Given this list of marker genes Zfta, Gna14, Gm31166, Tex54, Gm14963, Hnrnpul2 (heterogeneous nuclear ribonucleoprotein U-like 2), Gal, Gstp2, Vwce, Or5b108 (NCBI Gene Id 258688), Gm19224, Ppp2r5b, Gm22272, Fads1, Rpl37-ps1, Nrxn2, Slc29a2, Gm30082, B4gat1, Nscme3l, Dpp3, Or10v9, Dtx4, Or9i16, Cabp4, Or5b99, Tcirg1, Nudt22, Ms4a6d, Gm18842, Mir6984, Eml3, Or10q3, Snora57, Top6bl, Gm7798, Or9i1b, 2210404E10Rik, Gm31070, Ms4a4d, Cfl1, AW112010, Or5an8-ps1, 1700061A03Rik, Tbx10, Gm42068, Mir496b, Wdr74, Ehbp1l1, Ms4a5, Gm25894, D330050I16Rik (RIKEN cDNA D330050I16 gene), Or5b110-ps1, Gm22680, Yif1a, B3gat3, Gm15967, Mrpl21, Cnih2, Gm9750, Olfr1435-ps1, Zfpl1, Clcf1, Tut1, Gm5513, Or5b118, Cpt1a, Gm8184, Syt12, Flrt1, Zbtb3, Or4d11, Keg1, Tmem258, Stx3, Cep78, Kcnk4, Tmem179b, Ms4a8a, Slc3a2, Sart1, Rbm4b, Slc22a29, Snhg1, Gm17068, Slc25a45, Fen1, Ptgdr2, Slc22a12, Gm53055, Scyl1, Banf1, Eif1ad, Nudt8, Or5aa2-ps1, Lpxn, Or5b12, Batf2, Gm6192, Lbhd1, 4930524O05Rik, Vps37c, Or10w1, Tmem216, Ndufv1, Olfr1488-ps1, 4930526L06Rik, Ms4a4a, Ms4a3, Eef1g, Tmem132a, Cdca5, Atl3, Tm7sf2, Map3k11, Gm7096, Or5a1, Rbm4, Olfr1481-ps1, Ighmbp2, Rps6kb2, Syt7, Ms4a15, Asrgl1 (asparaginase like 1), Efemp2, Cdc42bpg, Gpr152, Ccdc87, Or5b94, Or5b113, 1810055G02Rik, Or5q1-ps1, Coro1b, Mir6988, Gm8034, Mir6994, Ppp6r3, Ptprcap, Majin, Or5b12b, Plaat5 (NCBI Gene Id 73514, phospholipase A and acyltransferase 5), Or5an10, Brms1, Gm10814, Atg2a, Dpf2, Kcnk7, Bscl2, Mir192, Bbs1, Or10q12, Tmem151a, Mir194-2, Scgb1a1, Gm5242, Tbc1d10c, Tmem134, Fermt3, Chrm1, Aip, Stxbp3-ps, Esrra, Gm8369, Or5a3, Or4d29-ps1, Ms4a14, Znhit2, A430093F15Rik, Ppp1ca, Or5bb10, Or5b116, Gm8189, Or5an1b, Or5x2-ps1, Grk2, Lgals12, Malat1, Or5b96, Ms4a13, Or5b124, Psat1, Mta2, Fam89b, Neat1, Gm23246, Ms4a20, Or9i13-ps1, Gm3188, Gm44505, Ms4a12, Pcx, Ap5b1, Nxf1, Or9i1, Fads3, Drap1, Ints5, Ms4a4b, Ccdc86, Or5b121, Or9i14, Rnaseh2c, Mpeg1, Stip1, Rad9a, Ctsf, Carns1, Kmt5b, Oosp2, Aldh3b3, Tle4, Or5b117, Pfpl, Trmt112, Or5b101, Snx32, Klc2, Lrp5, Or5x1-ps1, Rbm14 (NCBI Gene Id 71771, RNA binding motif protein 14), Snord3b-ps1, Vps51, Or5a21, Slc22a26, Npas4, Mus81, Or5b109, Rplp1rt, Or10q1, Or5aa3-ps1, A930001C03Rik, Mir6989, Zp1, Or5b100-ps1, Fau, Gm36608, Gm49405, Snord22, Acy3, Ms4a2, Aldh3b2, Sf3b2, BE692007, Gm24452, A330040F15Rik, Gm10817, Ahnak, Uqcc3, Gm46658, Prpf19, Gm50359, Cpsf7, Oosp1, Gm550, Gpr137, Ms4a4c, 2410152P15Rik, Gm22744, Or5b97, Or10w3, Gm10819, Slc22a8, Dnajc4, AI837181, Fosl1, Hmgb1-ps4, Tesmin, Gm19312, Or5b3, Plcb3, Oosp3, Or5b102, Ccs, Or5an1, Gm30042, Slc22a20, Gm2106, Olfr1482-ps1, Or5an11, Gm6425, Or5b122, Cblif, Or4d6, Tmem223, Gm5512, Scgb2a2, Mir6991, 1700030N03Rik, Gstp1, Cd6, Gm5510, Gm25443, Tkfc, Naaladl1, Gm17552, Olfr1421-ps1, Men1, Tmem109, Slc22a19, Mrpl11, Or5b95, Tsga10ip, Slc22a6 (solute carrier family 22 (organic anion transporter), member 6), Ovol1, Gm6501, Rin1, 1500032F14Rik, Or5b119, Gpha2, Gm5511, Ganab (NCBI Gene Id 14376), Ehd1, Rom1, Or5b107, Ccdc85b, Tmem138, Gm16437, Mrpl16, Ankrd13d, Cd5, Pcna-ps2, Rce1, Mrpl49, Gm24124, Taf6l (TATA-box binding protein associated factor 6 like), Or4d10b, Gm10353, Ppp1r14b, Ltbp3, Plaat3 (phospholipase A and acyltransferase 3), Zdhhc24, Or5bb12, Saxo4, Pitpnm1, Gm16274, Or10v5, Gm3329, Gm15968, Lrrc10b, Or5aa1-ps1, Sdhaf2, Or5u1-ps1, Or10q1b, Cd248, Mir5136, Or5b98, Capn1, Gm336, Ccdc88b, Gm25432, Gm50432, Or9i2, Mir5046, Gm16066, Best1, Kat5, Mir6990, Rcor2, Spindoc, Map4k2, Kdm2a, Gm17802, Gm10802, Or4d10, Fkbp2, Or10v1, 2010003K11Rik, Arl2 (NCBI Gene Id 80563), Rasgrp2, Or5b106, Gm2141, Myrf, Gnaq, Rhod, Osbp, Gm36787, Syvn1 (synovial apoptosis inhibitor 1, synoviolin), Zfp91, Ndufs8, Gm45928, Lrfn4, Slc22a30, Or5an6, Ddb1, Mir6985, Mir6986, Or5b120, Mir6992, Polr2g, Ms4a6c, Or5b115-ps1, Pygm, Gm26183, Gm24521, Or5b123, 4930481A15Rik, Macrod1, Gm42064, Aldh3b1, Gm42067, Gm6445, Or9d1-ps1, Gm24453, Bad, Gm14966, Gm2617, Or5b103-ps1, Or9i15-ps1, Tmem262, Gstp3, Gm28347, Gm25855, Gm19261, Snx15 (NCBI Gene Id 69024), Or5an1c, Sf1, Unc93b1, Ms4a18, Or5an9, Gm7105, Dagla, Gm6386, Or5b125-ps1, Vegfb, Otub1, Gm41804, Or9q2, Trpt1, Cdk2ap2, Fth1, Ms4a6b, Ms4a7, Gm14964, Gm4952, Or5b21 (olfactory receptor family 5 subfamily B member 21), Fads2, Ubxn1, Mir6987, Cdc42ep2, Gm19209, Sac3d1, Pga5, Prdx5, Chka, Cox8a, Ctsw, 1810009A15Rik, Slc22a27, Gm10212 (NCBI Gene Id 101055836), Stx5a, Gm6293, Tigd3, Or5b112, Gal3st3, Pola2, Rab11b-ps2, Slc22a28, Gm2518, Sipa1, Or5bc4-ps1, Or5b24, Naa40, Rela, Cntf, Ms4a19, Ssh3, Glyat, Rtn3 (NCBI Gene Id 20168), Or9q1, Rab1b, Or5b111, Gm10143, Gm19505, Gm50340, Or5b104, Or4z4, Gm23140, Peli3, Incenp (inner centromere protein), Olfr1485-ps1, Or1s2, Gm6252, Gm6365, Znrd2, Gm23940, Cst6, Frmd8, Pold4, Gm36913, Fibp, Pacs1, Gm14965, Or5b114-ps1, Cyb561a3, 1700105P06Rik, Rab3il1, Gng3, Cabp2, Pcnx3, 1810058N15Rik, Doc2g, Mir6993, Frmd8os, Ms4a1, Gm7074, Gm5692, Or5b105, Or4d10c, 9830166K06Rik, Gm17227, Catsperz, Sptbn2, Ttc9c, Mark2, Fam111a, Ms4a10, Patl1, Gm8222, Slc15a3, Gm21992, Lrrn4cl, Gm8157, Actn3, Catsper1 (NCBI Gene Id 225865), C130060C02Rik, here is a description of the gene set: studied in species Mus musculus Mouse Gene Set: chr19A